Given this list of marker genes GRM7, CPA6, NEK1, KDM5A (NCBI Gene Id 5927), RNU4-2, RNU4ATAC, CAMTA1, ABCA7, BICRA, SLITRK2, here is a description of the gene set: studied in species Homo sapiens Human Gene Set: HP_HIPPOCAMPAL_ATROPHY Hippocampal atrophy Partial or complete wasting (loss) of hippocampus tissue that was once present.